The following is a description of a gene set: Any process that activates or increases the frequency, rate or extent of DNA catabolic process. Human Gene Set: GOBP_POSITIVE_REGULATION_OF_DNA_CATABOLIC_PROCESS species: Homo sapiens, and this is the list of marker genes: BAX, ENDOG, HSF1, IL6, GATA5